Given this list of marker genes TOMM5 (translocase of outer mitochondrial membrane 5), GAREM2, EPM2AIP1, CPLX1, RNF152, LIAS, PGAM5, WDR33, SHTN1, DYNLRB1, EID1, CIAO1, POLDIP2, PEG10, WDR87 (NCBI Gene Id 83889), ADORA3, HNRNPU, RAB22A, LGALS3BP, IRAG1, PRADC1, GIGYF2, CELF5, C17orf49, ETF1, VPS35, CIC, WDR72, SLC13A1, HECTD4, ZNF468, NCKAP1L, CDC27, MAD2L1, FERMT1, OGDH, NFASC, CAPN6, ZNF584, UPF2, ZNF765, CADPS, CREB1, COL5A1, FANCE, SOSTDC1, KRTAP4-1, PRXL2C, SRSF11, FOXP2, EEIG2, FRAS1, GABRG3, DKK1, AAK1, N4BP1, USP4, ABCB5, CIDEA, STRN, KIF3B, AHSP, TSPYL1, KDM2B, DPY30, CSF2RB, SLC29A2, MACROH2A1, here is a description of the gene set: Human Gene Set: MIR493_3P species: Homo sapiens from publication Chen Y, Wang X (PMID 31504780) Genes predicted to be targets of miRBase v22 microRNA hsa-miR-493-3p in miRDB v6.0 with MirTarget v4 prediction scores > 80 (high confidence targets).